The following is a description of a gene set: Triplicates preparations of RNA from day 10 DC's. Experiment is described in Wong et al 2003 Nat. Immunol. Human Gene Set: GSE557_WT_VS_I_AB_KO_DC_DN species: Homo sapiens from publication Wong AW, Brickey WJ, Taxman DJ, van Deventer HW, Reed W, Gao JX, Zheng P, Liu Y, Li P, Blum JS, McKinnon KP, Ting JP (PMID 12910265) Genes down-regulated in dendritic cells: wildtype versus I ab-/- mice., and this is the list of marker genes: COPRS (NCBI Gene Id 95076), DDIT3, SUPT16H, EIF4H, PUM2 (NCBI Gene Id 23369), OTULIN, CNOT9, TMEM11, NUP133, IFT57, RFC2, CDC34, BCL2L14, PEX7, MPHOSPH6 (NCBI Gene Id 10200), CEP43, VPS35, IMPA2, EMILIN2, NEK1, PFDN6, SMC3, RNF7, CDCA5, LHFPL4, RAD23B, NME1, TAF4, FUNDC1, CPE, FAM117B, AGPAT5, AP3S1 (adaptor related protein complex 3 subunit sigma 1), FAM133B, TTC7B, PPP2CA, FAAP24, CDC42EP3, BTBD8, PPP6C, SART3, VPS4A, FABP5, ERI1 (exoribonuclease 1), SLC66A3, SPAG7, BEND5, PSMA6, POLR2C, MRPS22, GCOM1, IGF2BP3, MICU2 (NCBI Gene Id 221154), FDFT1, SLC25A13, LRRC2, NAA10, NPLOC4, SMCO1, GMNN, NAA50, SDE2, FAM76B, FYTTD1, PSMD13 (NCBI Gene Id 5719), CS, SLAIN1 (NCBI Gene Id 122060), UBA3, FAM83F, OAZ1, RIF1, CASKIN2 (NCBI Gene Id 57513), AFF4, DNAH11, PRSS16, PIDD1, TEX9, CDH13, DUSP18, CCNE1, KCTD9, RIPK3, SCLT1, ZNF496, RARS1, SLC43A3, MCM9, ADGRL2, LBR, GTF3C4, TNFAIP8, TTC32, SUGT1, SLC25A25, INTS13, EIF2S2, UBE2A, MRPL27, PSMA1, FRMD5, CNTROB, NLRX1, HSPH1, CNOT2, UQCC2, ENY2, KIAA1958, MIS18A, IFT80, NHP2, KCNS1, CEP76, RPAP3, NXF2, NRBF2, PEMT, NFE2L2, EHBP1L1, NOP16, PRADC1, SFMBT1, C15orf39, IL21R, DUSP5, RECQL4, PHF5A, YWHAQ, BBS2, EGR2, NANOS1, MFSD13A, PFKFB1, TFG, XRN2, IRAG2, SARNP, EHD3, RAB9A, CCT3 (chaperonin containing TCP1 subunit 3), ELMO1, MRPS25, CRPPA, PDHX, NACC1 (NCBI Gene Id 112939), GLA, FADS1, PDP1, SFR1, RAD51B, SPEF1, RYBP, LSM14A (NCBI Gene Id 91161), TONSL, CLDN2, MAP2 (microtubule associated protein 2), NDE1, PSIP1, MAP9, WBP4, SFPQ, TIMM23, FCHSD2, MRPL57, ZW10, TRA2B, CCDC92, POLG, ZFP36L2 (ZFP36 ring finger protein like 2), PPP2R5A (NCBI Gene Id 5525), RNASEH2B, PMM1, YES1, TIMELESS, SLAMF7, LAP3, CDKN2A, PPIH, SIRT1, PGRMC2, LIN54, ITPA, BUB3, GABPB1, PRDX2, IL2RB, ARHGAP6, NMNAT3, GOPC (golgi associated PDZ and coiled-coil motif containing), NCBP3, PPP2R5D (protein phosphatase 2 regulatory subunit B'delta), NR4A3, TGIF1, RIC3, PRMT5, OTUD6B, SNAP23, ZNF664, MROH2A, LIN7C, SLC16A1